The following is a description of a gene set: Excessive growth of the calvaria. Human Gene Set: HP_CALVARIAL_HYPEROSTOSIS species: Homo sapiens Calvarial hyperostosis, and this is the list of marker genes: IDUA, HNRNPA2B1, VCP, PRKAR1A, AKT1, HNRNPA1, COX4I2, COL1A1, SLC39A14